Given this list of marker genes Slc43a2, Slc7a5, Slc43a1, Slc3a2, Slc38a9, Slc7a8, here is a description of the gene set: Enables the transfer of L-leucine from one side of a membrane to the other. L-leucine is 2-amino-4-methylpentanoic acid. Mouse Gene Set: GOMF_L_LEUCINE_TRANSMEMBRANE_TRANSPORTER_ACTIVITY species: Mus musculus